Given this list of marker genes Jak1, Jak3, Ptprc, Stat5a (NCBI Gene Id 20850), Stat6, Il4ra, Parp14, Ptpn2, Cd40, Il4, Cd300lf, here is a description of the gene set: Mouse Gene Set: GOBP_INTERLEUKIN_4_MEDIATED_SIGNALING_PATHWAY species: Mus musculus The series of molecular signals initiated by interleukin-4 binding to its receptor on the surface of a target cell, and ending with the regulation of a downstream cellular process, e.g. transcription.